Given this list of marker genes NSD2, COL9A3, IFT80, IHH (NCBI Gene Id 50819), POC1A, FGFRL1, PTPN22, PCYT1A, LRP4, EXT2, PHYH, CANT1, PIGS, PRG4, COL9A1, RAB3GAP2, FZD2, BMP6, RSPRY1, FGF9, CSPP1, PTPN2, SHH, KIAA0753 (NCBI Gene Id 9851), ANAPC1, ROBO1 (roundabout guidance receptor 1), PQBP1, BPNT2, DDR2, TP63, ACVR1, REV3L, GLB1, NEPRO, PTCH1, RPS6KA3, CLCN7 (NCBI Gene Id 7814), DCHS1 (dachsous cadherin-related 1), AKT1, PPOX, SLC25A24, NOTCH1, EXT1, FBLN1, BMP2, PEX7, PIK3CD, COMP, NPR3, SCARF2, FLNB, MAFB, B3GAT3, FBXL3, MEG3, INTU, PDE6D, TWIST2, FANCD2, GNAS-AS1, ERI1, HHAT, RIPK4, FERMT1, MKKS, HOXA13, DLL4, EIF4A3, COL11A2, RAB23, SMARCA2, ZIC1, ROR2, SPARC, TRIP11, RNF13, PCNT, PTDSS1, P3H1, INPPL1, TBX3, DHCR7, CWC27, GNAS, GJB6, SH3PXD2B, ADAMTSL2, ASXL2, TCF12, HOXD13, COL3A1, TRPS1, PTH1R, LAMA5, COL9A2, CPLX1, KIAA0586, NONO, B3GLCT, PTHLH, TFE3, MAP3K7, CHSY1, PLXND1, VPS13B, RAB33B, RUNX2, CLDN16, KIF22, FIG4 (NCBI Gene Id 9896), LBR, IFT140, KIF7, XYLT1, TMEM216, FGFR3, TOMM7, ARHGAP31, KCNJ2, RMRP, MYL11, RECQL4, IFT27, SRCAP, SIL1, TWIST1, VAC14, CTBP1, IL2RA, ESCO2, DNA2, TOPORS, STAT4, GLI3, FAM149B1, CCN2, SHOX, FANCI, APC, CD96, TMEM231, NSD1, NPR2, IFT52, EXTL3, HDAC8, SMC3, PDE4D, SOX9 (SRY-box transcription factor 9), IL2RB, LTBP3, SLC39A13, HDAC4, FBN1, RNU4ATAC, COG4, SF3B4 (NCBI Gene Id 171), BMPR1B, FAT4, SALL1, FLNA, PRKAR1A, SVBP, DYM, DOCK6, XRCC2, GDF5, HFE (homeostatic iron regulator), LETM1, MEGF8, NEK1, ADAMTS10, SLC26A2, TCTN3, SMC1A, COL2A1 (collagen type II alpha 1 chain), FMR1, B3GALT6, CHST3, BGN, FGFR1, FGF16, DLK1, DNMT3A, TAF6, POR, SRY, KL, RBPJ, SALL4, PRKG2, SETBP1, ASXL1, TRIO, IFIH1, OFD1, LMBR1, CD247, TGDS, PRMT7, BRD4, NIPBL, GPX4, TBX5, KNSTRN, MMP2, NHS, RTL1, MMP14, GUSB, PORCN, MYSM1, ANKRD55, MATN3, SMOC1, EOGT, GALNS, NFIX, NOG, LONP1, STX16 (syntaxin 16), VPS35L, CPLANE1, PDE3A, LRP5 (LDL receptor related protein 5), DONSON, RAD21, BHLHA9, WNT7A, here is a description of the gene set: Any abnormal shape or structure of the metacarpal bones. Abnormal metacarpal morphology Human Gene Set: HP_ABNORMAL_METACARPAL_MORPHOLOGY species: Homo sapiens